The following is a description of a gene set: An enriched environment is known to promote structural changes in the brain and to enhance learning and memory performance in rodents. To better understand the molecular mechanisms underlying these experience-dependent cognitive changes, we have used high-density oligonucleotide microarrays to analyze gene expression in the brain. Expression of a large number of genes changes in response to enrichment training, many of which can be linked to neuronal structure, synaptic plasticity, and transmission. A number of these genes may play important roles in modulating learning and memory capacity. Mouse Gene Set: RAMPON_ENRICHED_LEARNING_ENVIRONMENT_EARLY_UP species: Mus musculus from publication Rampon C, Jiang CH, Dong H, Tang YP, Lockhart DJ, Schultz PG, Tsien JZ, Hu Y (PMID 11070096) Genes up-regulated in the brain cortex of mice that were exposed to an enriched learning environment for one day., and this is the list of marker genes: Dnmt1, Tlk1, Ap2m1, Hnrnpm, Phc2, Tac1, Vamp2, Hspa5, Rhoa, Mfap5 (NCBI Gene Id 50530), Ptgds, Calm3, ENSMUSG00000135795, Map4k3, Trim25